Given this list of marker genes SYNE2, SUN1, SYNE3, SUN2, SYNE1, here is a description of the gene set: The binding activity of a molecule that brings together a cytoskeletal protein or protein complex and a nuclear membrane lipid or membrane-associated protein, in order to maintain the localization of the cytoskeleton at a specific location of the nuclear membrane. Human Gene Set: GOMF_CYTOSKELETON_NUCLEAR_MEMBRANE_ANCHOR_ACTIVITY species: Homo sapiens